Given this list of marker genes SFXN1, SLC7A8, SLC3A2, SLC1A4, SLC36A3, SLC38A3, SLC36A1, SLC36A4, SLC36A2, here is a description of the gene set: Enables the transfer of L-alanine from one side of a membrane to the other. L-alanine is the L-enantiomer of 2-aminopropanoic acid. species: Homo sapiens Human Gene Set: GOMF_L_ALANINE_TRANSMEMBRANE_TRANSPORTER_ACTIVITY